The following is a description of a gene set: Human Gene Set: GSE3337_CTRL_VS_16H_IFNG_IN_CD8POS_DC_UP from publication Orabona C, Puccetti P, Vacca C, Bicciato S, Luchini A, Fallarino F, Bianchi R, Velardi E, Perruccio K, Velardi A, Bronte V, Fioretti MC, Grohmann U (PMID 16339401) studied in species Homo sapiens Genes up-regulated in comparison of untreated CD8+ dendritic cells (DC) at 16 h versus those treated with IFNG at 16 h. Although much is known on the transcriptional profiles of dendritic cells (DCs) during maturation, the molecular switches critical for the acquisition of a tolerogenic program by DCs are still obscure. In the present study, we explored the gene expression pattern of CD8+ DCs purified from the mouse spleen and treated with interferon (IFN)-gamma. The cytokine, indeed, potentiates the tolerogenic potential of this DC subset via induction of the immunosuppressive tryptophan catabolism mediated by indoleamine 2,3-dioxygenase (IDO). By comparing the expression of the IFN-gamma-modulated genes in IDO+ versus IDO- murine DCs, we found a consistent and selective association of the IDO-competent phenotype with the down-modulation of the Tyrobp gene, encoding the adapter molecule DAP12. IFN-gamma-mediated down-modulation of this gene involved IFN consensus sequence binding protein (ICSBP), a transcription factor also known as IRF-8. While silencing of Tyrobp conferred IDO functional competence on IDO- DCs, silencing of Icsbp1 in IDO+ cells completely abolished IDO expression and function. In parallel, silencing of TYROBP conferred IDO competence on human IDO- DCs while silencing of IRF8 impaired IDO expression and activity in human IDO+ DCs. Therefore, the same small set of molecular switches controls IDO competence in murine and human DCs., and this is the list of marker genes: UBA5, HP, PIMREG, STAB1, CD14, DBP (NCBI Gene Id 1628), CLCC1, ANKRD28, H6PD, SMAD5, NUDT5, ASPRV1, KRT34, MUSK, TPM2, CCR9, ADAMDEC1, EXOSC4, KLF7, IER3, DNAJB4, HSD17B4, IL18, GNPTAB, GSTM5, COX5A, PRKCD, PTAFR, ANXA5, ID3 (NCBI Gene Id 3399), HMOX1, ARHGAP9, CD300C, SHH, UBE2K, PARP1, CRYL1, BIRC3, GAB1, PDGFRB, ADGRG3 (NCBI Gene Id 58870), SLPI, RABEP1, GNA12, DPP7, PATJ, EML5, MYL11, AFF4, ZNF239 (zinc finger protein 239), APOE, ADAMTS1, KDELR1 (KDEL endoplasmic reticulum protein retention receptor 1), B4GALT6, APOC2, USP25, NECAP1, HOXA1, SNX5, MMP12, TP53INP2, VEGFA, TYROBP, ZMAT3, TOP3B, ACP5, CTSV, CCDC28B, TMEM165, CP, METTL3, S100A4, ZNF277, FASLG, STK3, SH3GL1, TRIO, PLBD1, IL5RA, RTN1, IL1RAP, NCF4, ASH2L, ZSCAN21, PRNP, PTPRS, FCER2, SPRYD4, SGPP1, CLEC4A, ATOX1, NFS1, LXN, TMEM11, HBG2, JKAMP, TMEM205, VCAM1, RGL1, IDH3A, CTSD, TMEM176B, ERGIC1, RAMP1, SFT2D1, CDCP1, FZD1, NAV1, EVI5, FLT3, COX6A2, PIP4K2A, MRC1, VCAN, ETS2, JARID2, IL4I1, SPART, NNT, FH, PLXND1 (NCBI Gene Id 23652), NXPH2, FGR, ABCC1, RAB3IL1, PVT1, CDH9, EREG, ACOX1, NCKAP1L, COMTD1, ZFP37, DNTT, LUC7L, MFAP4, CFP, SLC44A1, LMNA, NDRG4, IL13RA1, CD44, TNFRSF4, ASAP1, IFI27, IRAG1, HEBP1, NME1, CDH11, TSEN15, C5AR1, CEBPA, C1QTNF12, MESP2, HSPA1A, IL1B, DAP, YJU2B, F10, APOA5, CALCB, C3AR1, BPHL (biphenyl hydrolase like), UBE2L3, EMP1, DNAJC4, SETD4, GALNT1, EFNB2, ANKRD10 (NCBI Gene Id 55608), CTSB, QRSL1, UFD1, VTI1A, SOX4, ACSM2A, SERAC1, UTY, PPFIA4, SERPINB4, MID1 (midline 1), GCAT, FZD4, NSF, RTTN, PRDM1, CD93, HLA-DQA1, MAN2B1, VPREB3, ANGPTL2, CCL22, SYNGR1, STARD3, KLHL21, ROGDI, ENO3, TMEM37, TMEM45A, BDNF, CNTRL